Given this list of marker genes RGS2, ATP1A1, SNRPD3, LMO4, EGLN3, NEAT1, PNPT1, COLEC12, PID1, TMEM242, KLF9, CYP1B1, FOXF2 (forkhead box F2), TRIM2, SLC2A1, ARC, MAOB, ASPN, CIDEA, WWP1, AHNAK, LY6D, PMAIP1, ARHGEF26, CALCRL, TANC1, MAF, LRRK1, UBE4A, PDGFD, BDH2, SYNPR, FNDC3B, TMEM100, NT5E, BNIP3, PENK, ACOT1, MAP3K6, OR2AK2, CEBPD, SMOC1, SLITRK6 (NCBI Gene Id 84189), ADAMDEC1, ZFAS1 (ZNFX1 antisense RNA 1), TAC1, COL23A1, LAMP2, MKX, ITGB4, TP63, BCL6, FZD7, TMEM45A, CEACAM1, TP53INP1, EMD, TSPAN1, KLF15, ERRFI1, ARL6IP5, TFAP2C, ALDH1A3, SFRP2, STAT5A (signal transducer and activator of transcription 5A), PLA2G4A, NCOA1, FABP4, TAF1D, RASL11B, AVPR1A, DNER, SOX9, GADD45G, WIF1, SESN1, CDH1, FGF10, LOXL2, RALY, NLGN1, SHH, FKBP5, MPST, LRP4, PDLIM3, IGFBP2, CXCL14, LMCD1, TLE1, PROS1, SETBP1 (NCBI Gene Id 284262), CYS1, DCLK2, FAM9A, PGK1, GLUL, PDGFC, SLC39A8, EFEMP1, FILIP1 (NCBI Gene Id 27145), EPHA3, HSPA1A (heat shock protein family A (Hsp70) member 1A), FGFR2, CFAP144, MYF5, COL24A1, MAFF, KCND2, COL4A6, PGAM1, here is a description of the gene set: Genes up-regulated in the urogenital sinus (UGS) of day E16 females exposed to the androgen dihydrotestosterone for 12 h. species: Mus musculus from publication Schaeffer EM, Marchionni L, Huang Z, Simons B, Blackman A, Yu W, Parmigiani G, Berman DM (PMID 18794802) Human Gene Set: SCHAEFFER_PROSTATE_DEVELOPMENT_12HR_UP Cancer cells differentiate along specific lineages that largely determine their clinical and biologic behavior. Distinct cancer phenotypes from different cells and organs likely result from unique gene expression repertoires established in the embryo and maintained after malignant transformation. We used comprehensive gene expression analysis to examine this concept in the prostate, an organ with a tractable developmental program and a high propensity for cancer. We focused on gene expression in the murine prostate rudiment at three time points during the first 48 h of exposure to androgen, which initiates proliferation and invasion of prostate epithelial buds into surrounding urogenital sinus mesenchyme. Here, we show that androgen exposure regulates genes previously implicated in prostate carcinogenesis comprising pathways for the phosphatase and tensin homolog (PTEN), fibroblast growth factor (FGF)/mitogen-activated protein kinase (MAPK), and Wnt signaling along with cellular programs regulating such 'hallmarks' of cancer as angiogenesis, apoptosis, migration and proliferation. We found statistically significant evidence for novel androgen-induced gene regulation events that establish and/or maintain prostate cell fate. These include modulation of gene expression through microRNAs, expression of specific transcription factors, and regulation of their predicted targets. By querying public gene expression databases from other tissues, we found that rather than generally characterizing androgen exposure or epithelial budding, the early prostate development program more closely resembles the program for human prostate cancer. Most importantly, early androgen-regulated genes and functional themes associated with prostate development were highly enriched in contrasts between increasingly lethal forms of prostate cancer, confirming a 'reactivation' of embryonic pathways for proliferation and invasion in prostate cancer progression. Among the genes with the most significant links to the development and cancer, we highlight coordinate induction of the transcription factor Sox9 and suppression of the proapoptotic phospholipid-binding protein Annexin A1 that link early prostate development to early prostate carcinogenesis. These results credential early prostate development as a reliable and valid model system for the investigation of genes and pathways that drive prostate cancer.